The following is a description of a gene set: Mouse Gene Set: GOBP_SYNAPTIC_TRANSMISSION_CHOLINERGIC The vesicular release of acetylcholine from a presynapse, across a chemical synapse, the subsequent activation of dopamine receptors at the postsynapse of a target cell (neuron, muscle, or secretory cell) and the effects of this activation on the postsynaptic membrane potential and ionic composition of the postsynaptic cytosol. This process encompasses both spontaneous and evoked release of neurotransmitter and all parts of synaptic vesicle exocytosis. Evoked transmission starts with the arrival of an action potential at the presynapse. species: Mus musculus, and this is the list of marker genes: Chrnb3, Rapsn, Tacr1, Tacr2, Chrna7, Chrna6, Adora2a, Ngfr, Slc18a3, Chrna5, Chrnb2, Htr2c, Camk2b, Slc5a7, Anxa9, Lypd1, Chrna1, Chrna3, Dmd, Nalcn, Ric3, Lynx1, Tac1, Chrna4, Lama2, Musk, Uts2, Chrna10, Chrnb1, Chrna2, Chrm3, Htr6, Cacna1a, Chrnb4, Ifng